Given this list of marker genes HSD17B4, IL6ST, GNRHR (NCBI Gene Id 2798), KDM5A, INTU (NCBI Gene Id 27152), ADNP, FLNA (NCBI Gene Id 8272), TPM2, UBR7, TMEM107, PSAT1, RPL9, IFT27, EBP (EBP cholestenol delta-isomerase), EPG5, NBAS, MAPK8IP3, FAR1, AFF3, PTRH2, ANK1, RSPRY1, DICER1, FGF20, CTNND1, MGAT2, FANCE, RAI1, TBC1D24, RPS15A, LYN, ZIC1, DDX3X, SMAD3, BBS4, TGFBR1, ALDH18A1, CCDC47, MRPS14, HEPACAM, POGZ, MED13L, SMCHD1, TFE3, H4C11, PYCR1, ACY1, POLR3A, DNMT3A, IFT74, RBM10, TDO2, PYCR2, FLCN, CPLX1, LRP4, KATNB1, LETM1, SIK3, LIG4, POR, PTH1R, SHANK3, EFNB1, EDEM3, FOXE3, PITX1, PIGL, PACS2, TRAPPC9, SUPT16H, ANAPC7, ESCO2, TCTN1, SPEN, PIK3CD, ASNS, TWIST1, ERCC2, TPRKB, KRAS, APC, AGA, ALG6, NCDN, MICU1, KIAA0586, BRAF, LMNB1, NAA10, IDUA (alpha-L-iduronidase), TCIRG1, H4C3, RPS24, UBE2A, SOS1, HMGA2, FREM2, PROKR2, TAOK1, ADA2, ARL6, RASA2, OGT, PROK2, LZTFL1, FBN1, BBS1, IFT43, ATP6V1A, ODC1, AHDC1, SCYL2, BRCA2, PLCB3, HEY2, IGLL1, LRRC8A, LRP5, PRDM13, FANCC, RPS6KA3, RMRP, SLC25A24, HID1, RPL15, ACTA2, SLC32A1, GALNT2, H3-3A, FIBP, SOST, AP4S1, DPF2, FLII, PIGG, RPL27, GFRA1, SKIC3, CLCN3, RPL8, UFC1, SUZ12, PEX1, INTS11 (NCBI Gene Id 84139), KLF13, CDK19, THRA, DVL1, IRX5, LBR, RPS29, DOCK6, RB1, GTF2H5, ZNF292, B3GLCT, ADAMTS15, RAC3, TMEM67, SLC29A3, CCDC32, MAGEL2, TACR3, TCOF1, TMEM53, MYPN, PDZD8, LMBR1, BMP2, TCTN3, CAMTA1, RNU4-2, CHRNG, INSR, UFD1, BBS12, MYLK, TGFBR2, NSMF, C12orf57, SHOC2, PPP2R1A (protein phosphatase 2 scaffold subunit Aalpha), SPRED1, COG3, TBR1, RPL18, FGFR1, DDX6, MKS1, SMAD2, WDR4, IL11RA, SIX2, FRAS1, B3GAT3, GRIP1, KCNJ5, TRIP4, MAPRE2, DPYSL5, SLC2A10, WNT5A, ZBTB24, RNF113A, FGFRL1, GPAA1, INTS1, COL2A1, PAX3, KCNJ2, MMP2, COX7B, RFWD3 (NCBI Gene Id 55159), ITGA3, RLIM, DLX4, WNT9B, RSRC1, PRKAR1A, PEX5, NF1, AIFM1, FUCA1, RYR1, KATNIP, DHCR7, TOGARAM1, HRAS, KDM1A, IFT140, MPLKIP, TMCO1, RAB34, RUSC2, B4GALT1, CENPF, CD79B, KBTBD13, ERMARD, SLC26A2, NALCN, HBA2, CTCF (CCCTC-binding factor), FH, PGAP2, JMJD1C, BCORL1, TBX15, SMO, HACE1, MAN1B1, DPM1, PIK3R2, DDX59, PIK3CA, TASP1, GP1BB, PHACTR1, JARID2, TMEM216 (NCBI Gene Id 51259), ZBTB20, SPRY4, EP300, BLNK, CLCN7 (chloride voltage-gated channel 7), FANCI, TBX4, PSMD12, TUBA1A, RIPK4, LAGE3, CARS1, IQSEC2, PHIP, FANCG, COG8, GATAD2B, ALG8, TAPT1, NGLY1, ZSWIM6, WDR35, WASHC5, SPTBN1, TGDS, SMAD4, ALG1, BRCA1, NUP107, NEDD4L, TRIO, FOXP2, MOCS2, TAF1, MAP3K7, PIGO, PAFAH1B1, MAP2K2, CHSY1, COL3A1, SIN3A, PALB2, HIVEP2, AP1G1, ANKRD11, SLC1A4, ZMPSTE24, TBX1, NUP133, SMG9, FLNB, TSR2, ZFX, COL25A1, BBS9, ASXL2, PARS2, MAN2C1, NSD2, BRPF1, CDH1, RAPSN, KREMEN1, IPO8, TTC8, IL1RAPL1, RRAS, PITX2, EHMT1, MRAS, NAA80, GAD1, PPP1R21, RRAS2, ADK, TFAP2B, BNC2, UHRF1, NHLH2, CASK, NRAS, PUS1, B4GALT7, RAB23, TCF3, GNRH1, GJA8, THOC2, RET, NKX3-2, MYOD1, ERCC3, THUMPD1, CHST3, PRMT7, MUSK, ASCC3, CEP120, TXNL4A, RAD51, SPECC1L, ZEB2, SRD5A3, NSD1, QRICH1, CC2D2A, STAMBP, MN1, BRD4, RNF2, AUTS2, FOXC1, USB1, SH3PXD2B, ATRX, ALX1, THSD1, ACTB, SEMA5A, RIT1, MAN2B1, FANCD2, EFEMP2, CHRNA7, KLHL41, DVL3, GJA1, PIK3R1, CEP290, LEMD3, PPP1R12A, NSUN2, LZTR1, SLC37A4, GNS, RPS20, BMPER, NEB, NARS1, ELN, SCN1A (NCBI Gene Id 6323), WNK3, MCTP2, CREBBP, TCF12, NPHP1, WAC, TBCD, SCNM1, MYH11, COL11A1, PIGA, PDHX, FLI1, TRIM37, BICRA, ACTA1, SNRPN, EBF3, SLC25A12 (NCBI Gene Id 8604), TBCK, CDC42BPB, FANCL (FA complementation group L), MTOR, SMARCA2, CAPRIN1, GBA1, TP53RK, TTC7A, GPC3, XRCC2, ZIC3, PMM2, AARS1, HPDL, UBAP2L, PEPD, OFD1, GLI3, ASXL1, MAF, FBXO11, RPL11, POLR1A, PRPS1, RELN, NDE1, TNFRSF11A, NELFA, POLR2A, GATA6, WDR11, FAM20C, DCHS1, FOXE1, DPYD, ITGA8, RPS27, LRPPRC, SKIC2, ATP6V0A2, CEP19, GNPNAT1, FZD2, KISS1R, NUP88, SLC39A7, HERC1, RSPO2, ADAMTS3, SPRED2, TMEM94, ADGRG6, TCTN2, SNAP29, NFIX (NCBI Gene Id 4784), EIF5A, FGF3, TBCE, CDC42, FREM1, COL11A2, PDE6D, TRIM32, FGF17 (NCBI Gene Id 8822), GNE, PPP1CB, ERF, KIF7, MEGF8, FAM111A, STRADA, ACTL6B, JAG1, CDK10, SOX9 (NCBI Gene Id 6662), THSD4, XYLT2, RERE (arginine-glutamic acid dipeptide repeats), KDM6A, EXOSC9, CHRNA1, BPTF, AMER1, CSPP1, SLC45A1, KIF21A, TELO2, RPS26, COL1A2, KIF15 (NCBI Gene Id 56992), CIT, MED25, CNOT3, SH2B1, RPL31, ZMIZ1, STAT3, TWIST2, WDR26, SETD2, FGD1, SDCCAG8, INTS8, VPS51, TRIP12, COLEC11, ERCC4, PTCH1, RREB1, HEATR3, ZIC2, GNPTAB, RAP1GDS1 (Rap1 GTPase-GDP dissociation stimulator 1), CD79A, MBD5, PDGFRB, PTEN, FAM149B1, ZNF526, SLC18A3, PLP1, ATP6V1B2, EMC1, NOTCH2, PRORP, ZNF462, GPC4, DPH2, CHD4, PGAP3, RECQL4, DNAJC21, DEAF1, CCNK, MYCN, DOK7, AKT1, SEC24C, RPGRIP1L, UBE2T, HBA1, TBX2, GLE1, INPPL1, MOCS1 (NCBI Gene Id 7931), SEC23A, MARS2, GORAB, POLR1D, ALX4, WBP4, KCNMA1, IFT172, FRA10AC1, PAICS, EZH2, SMS, HS6ST1, BCAS3, CHD7, SPART, H4C9, CDH11, NONO, CTNND2, KMT2D, COL1A1, ALG9, KIAA0753, POLR1C, NKX2-6, BBS10, PIGN, CBL, ALX3, DEPDC5, NEK1, ITCH, PEX3, MAD2L2, KMT2A, OTUD5, RAF1, FGF8, DDR2, MID1, CHST14, DSE, ERGIC1, B9D1, RRAGC, SKI, RPL26, TXNDC15, YWHAE, KIFBP, RPGRIP1, TENM3, TOPORS, TRRAP, RAD51C, DHX9, HNRNPC, FAT4, PIGY, FGFR2, LRP2, PRKG1, NXN, RUNX2, YRDC, HNRNPH2, PPP3CA, AKT3, TGFB3, TAC3, TARS1, NOTCH3, CDH2, UBE3B, NKX2-5, ABCD4, GATA1, BMPR1A, ZMYND11, RAD21, ROR2, ACTG1, NFASC, AFF4 (NCBI Gene Id 27125), SCLT1, ASH1L, FILIP1, PDE4D, SPINT2, RPL35A, LTBP4 (NCBI Gene Id 8425), SLC39A13, WDPCP, NSRP1, PPP2R5D, AXIN1, BMP4, COG1, RPL35, MAPK1, CFAP418, SEMA3E, BUB1B, SPI1, CHD3, BGN, DEF6, CNTNAP2, KCNH1, MACF1, RPS28, FANCB, ZNF699, MASP1, PACS1, CENPJ, KNSTRN, TLK2, EXOC2, WDR73, BLTP1, PIGB, MED13 (mediator complex subunit 13), SEC24D, ZBTB18, KAT6B, SOX6 (SRY-box transcription factor 6), EED (NCBI Gene Id 8726), GTF2E2, MED12, IGHM, KNL1, EIF2AK3 (NCBI Gene Id 9451), TRAF7, HSPG2, CNTN1, SALL4, FOXP1, HIRA, COMT, PHGDH, CSNK2A1, MKKS, COL27A1, MARS1, ALDH6A1, BRCC3, RPL5, EPB41L1, FANCF, EXTL3, FIG4, RPS7, SET, ARVCF, FOXF1, VSX1, RNU4ATAC, TMEM237, BBS5, SPOP, ANTXR1, TBL1XR1, CACNA1G, PIGV, PIEZO2, CCND2, SLC12A6, CTBP1, CHD8, HELLS, KISS1, PUM1, VPS35L, TFAP2A, OSGEP, CDCA7, MEF2C, SCAPER, IFT56, SMARCD1, CDK13, PRKACB, GLB1, TPM3, KPTN, FGFR3, ATP6V1E1, PIGW, FBXO31, ZMYM2, ADAT3, GON7, HUWE1, DPH1, DHX37, SETD1A, MED27, EXT2, WARS2, RPS19, LOX, HDAC8, KCNN3, SLX4, RPS10, AVP, HNRNPU, CHRND, TMEM147, SLC35C1, BRIP1, CPLANE1, PPP2CA, TMEM231 (transmembrane protein 231), BBS2, FANCM, TGFB2, PTDSS1, CLCN6, FBXL4, RPS17, B9D2, HS2ST1, HDAC4, MYH3, VAC14, BBS7, TUBB, MFAP5, DBR1, DUSP6, GK, CTU2, SUFU, LMNA, POLR1B, GJA5, FANCA, SOS2, ACOX1, RAP1B, SIAH1, ANKH, GREB1L, PTPN11 (protein tyrosine phosphatase non-receptor type 11), TMEM138, ASXL3, UMPS, COLEC10, TONSL, NSMCE3, CCDC22, MED12L, ARID1B, HECTD4, RBL2 (NCBI Gene Id 5934), NRCAM, ALG13, MAT2A, CCBE1, PEX6, POC1A, PEX2, BCL11B, NR4A2, DNMT3B, WDR37, MAP2K1, BBIP1, PTCH2, SETBP1, here is a description of the gene set: Hypertelorism species: Homo sapiens Human Gene Set: HP_HYPERTELORISM Interpupillary distance more than 2 SD above the mean (alternatively, the appearance of an increased interpupillary distance or widely spaced eyes).